The following is a description of a gene set: Reactome Pathway: Mitochondrial calcium ion transport species: Homo sapiens Divalent calcium ions (Ca2+) are transported from the cytosol into the mitochondrial matrix and back out of the matrix into the cytosol. In the matrix, Ca2+ binds and allosterically regulates pyruvate dehydrogenase, isocitrate dehydrogenase, 2-oxoglutarate dehydrogenase, and possibly other enzymes. Matrix calcium is also observed to regulate release of caspase cofactors and calcium flux through channels on neighboring membranes, The pathway into the mitochondrion involves VDAC1, VDAC2, and VDAC3 in the outer membrane and the mitochondrial calcium uniporter (MCU) complex in the inner membrane. VDACs in the open conformation are anion channels. However in the closed conformation they transport Ca2+ from the cytosol to the intermembrane space. When calcium concentrations in the cytosol and intermembrane space are high, the MCU complex opens and transports Ca2+ from the intermembrane space to the mitochondrial matrix using the driving force of the membrane potential.<br>Efflux of Ca2+ from the matrix to the intermembrane space is catalyzed by the Na+/Ca2+ antiporter SLC8B1 (NCLX) located in the inner membrane. LETM1 is also observed to export calcium from the matrix to the intermembrane space by acting as an H+/Ca2+ antiporter, although somewhat contradictory results have been found in knockdowns of LETM1. Calcium in the intermembrane space may be transported to the cytosol by the Na+/Ca2+ antiporter SLC8A3 (NCX3), however the mitochondrial localization of SLC8A3 is controversial and SLC8A3 has a limited distribution among tissues. part of: Transport of small molecules, and this is the list of marker genes: LETM1, PHB1, MAIP1, VDAC3, PHB2, AFG3L2, STOML2, PMPCA, MICU2, VDAC2, MICU1, AKAP1, PMPCB, YME1L1, SLC8B1 (NCBI Gene Id 80024), MCUB, MCU, MICU3, VDAC1, PARL, SPG7, SMDT1, SLC8A3